The following is a description of a gene set: species: Homo sapiens A cortical network of highly dynamic tubules that are juxtaposed to the plasma membrane and undergo ring closure and tubule-branching movements. Human Gene Set: GOCC_CORTICAL_ENDOPLASMIC_RETICULUM, and this is the list of marker genes: OSBPL8, STIMATE, C2CD2L (NCBI Gene Id 9854), ARV1, EMD, STIM1, ASPH, TMEM201